The following is a description of a gene set: Human Gene Set: HP_CHRONIC_ACIDOSIS Longstanding abnormal acid accumulation or depletion of base. Chronic acidosis species: Homo sapiens, and this is the list of marker genes: CRELD1, SLC2A2 (solute carrier family 2 member 2), GSS, PDHA1, BCS1L